Given this list of marker genes ACSL4, CLVS1, TMLHE, SEMA6A, PYURF, EPYC, CKAP4, SLC25A16, POLR3D, IFI6, CADM3, NGDN, SIX2, QTRT2, POU3F4, NANOS2, WDR72, SLC2A1, THSD7B, KRTAP4-11, SEMA4G, ALK, HIC1, MECP2, SMARCD1, ASF1B, PIP4K2B, SC5D, HOXC4, FAM133B, POGLUT3, GPX5, PCDHGA12, DPPA4, SNAP91, CHL1, KNCN, POU1F1, TWSG1, GRIN2A, MCF2L, TMEM127, CACNA1C, ZDHHC9, ENAM, TTC5, UCP2, NFAT5, ARRB1, CARD17P, ARID4A, FGF23, GGA2, CDS1, GATAD2B, MRRF, SGCE, ZNF395, TCHHL1, ADGRL2, ARID2, PARP1, CCDC186, FAM222B, TGM6, MCC, BLOC1S4, KSR2, PLXNA4, ZNF575, HDAC9, NDE1, DCAF7, SETDB2, AP5M1, SP1, CNPPD1, SIK3, MAFG, ULK2, CACNB4, ARHGAP1, NAV1, B4GALT2, PSMA4, LGR6, DEPDC1, DDX60L, DOCK5, RNF141, B4GALNT1, ARRDC3, NKD1, PNPT1, SOX14, SCN4A, SMAD6, DENND11, LZTS3, SGTB, PBX1, FBXL16, GRM5, TMEM229A, ZBTB20, PATL1, USB1, PLCB1, SNX27, KPNA6, RAB2B, RIMS3, TBKBP1, ATAT1, SLC8A2, TRIM62, SHANK2, MIER3, NDST3, VSTM4, UBE2D2, ZNF282, PYROXD1, TRDMT1, RNF213, FNDC4, PARP11, FGD6, SUFU, FBXO3, NCOR1, SMG6, LRRTM3, PPT1, CA10, IGLON5, IGSF9B, CNTNAP2, C5orf22, PHF19, FCRLA, ELFN2, TRIM67, SLC4A7 (solute carrier family 4 member 7), PDK3, C1orf21, IL17A, CX3CR1, APEX2, PIK3R3, NOTCH3, ARMC7, KRT26, SYNGR1, PRKCB, UHMK1, STX17, RYK, PHGR1 (proline, histidine and glycine rich 1), SGO2, ATRN, ZDHHC22, LRRC15 (leucine rich repeat containing 15), TNRC6B, TDRD10, KCNAB1, CASP14 (NCBI Gene Id 8627), EPB41L4B, ZNF516, PRR18, ATF7, PDX1, MEN1, LINGO1, SYT5, FOXN3, CLEC4M, TUBB2B, BCL6B, FAM118A, FAM131B, MTMR3, GPC4, SPINT1, TMEM178B, MAGT1, RAF1, CD38, RNF150, RAD18, REPS2, EIF4EBP2, PDE10A, RGS5, POLE4, SMPX, RB1, BMPR2, ZC3H4, CARNS1, RHOBTB1, TMEM14A, GKAP1, MOSMO, ATXN1, KATNAL2, IGSF11, TMEM200A, SUB1, MOB3A, UBE2Z, VDAC3, MUCL3, LOXL2, RGS8, NREP, RBM23 (RNA binding motif protein 23), MAPKAP1 (NCBI Gene Id 79182), UBE4A, SENP8, INTS7, LASP1, PSME3, ZCCHC10, GATA6, GNRHR, IGFBPL1, LSM12, KLF12, KCNA1, LRP6, MTFR1L, CALM3, NR4A3, HAP1, KLHL14, MARCKSL1, RNF212B, CMTM2 (CKLF like MARVEL transmembrane domain containing 2), here is a description of the gene set: studied in species Homo sapiens from publication Chen Y, Wang X (PMID 31504780) Genes predicted to be targets of miRBase v22 microRNA hsa-miR-6077 in miRDB v6.0 with MirTarget v4 prediction scores > 80 (high confidence targets). Human Gene Set: MIR6077